The following is a description of a gene set: The chemical reactions and pathways involving N-acetylglucosamine. The D isomer is a common structural unit of glycoproteins in plants, bacteria and animals; it is often the terminal sugar of an oligosaccharide group of a glycoprotein. Mouse Gene Set: GOBP_N_ACETYLGLUCOSAMINE_METABOLIC_PROCESS studied in species Mus musculus, and this is the list of marker genes: Amdhd2, Nanp, Chst3, Chst4, Chst7, Hexb, Renbp, Gnpnat1, Extl2, Chst1, Chst5, Gne, Gnpda1, Gnpda2, Chst2, Nagk, Oga, Mgat3